Given this list of marker genes RNFT2, CD5L, TNMD, TINAG, ELMOD1, REEP5, XPOT, SAP18, LRRC8E, SF3B2, DPF1, HRH4, COLCA1, ZFP69, TTBK2, CLCN5, NHSL3, FAM89A, CDKL4, CLDN16, NPY1R, CALHM2 (calcium homeostasis modulator family member 2), CYP4V2, GSTO1, ZNF365, RPL27, SLC16A2, LPCAT1 (lysophosphatidylcholine acyltransferase 1), CYP3A4, KRT23, ASPM, COX7A2, MTCL1, KRTDAP, PIK3R6, CYFIP1, PAM, PNMT, WNT5A, LYPLAL1, TP53I11, AGMO, RAD51, EBI3, NME1 (NME/NM23 nucleoside diphosphate kinase 1), RNF11, RTL5, NTNG1, SMIM30, PXYLP1, CHL1, SLC22A14, GPLD1, CSDC2, ZDBF2, KRTAP8-1, ELAVL2 (ELAV like RNA binding protein 2), ZBTB18, NDNF, WDR83OS, VASH1, ESRRB, SPAG16, SH2D1A, CYP20A1, EGR3, ARHGAP28, BMP7, LGALS3, SMPDL3B, BCAT1, MELK, ALDH1L2, SYCP1, IGLON5, ANAPC13, DYNLL1, SQOR, STMN1, ASF1B, NDUFB9, PACC1, FKBP9, CNPY2, SLITRK4, NDUFV2, DNAH9, ZNF35, CCDC83, SCIN, PLPPR5, HDGF, TRIM3, MXRA7, SBK1, IFITM2 (NCBI Gene Id 10581), GCNT2, DGLUCY, EHF, NDUFA12, ITGB1, NRGN, TLR3, GLRX5, CRIP1, DLK1, MAP3K9, STON1, SLAMF6, EOMES, AMPD3, ARID3B (AT-rich interaction domain 3B), MPC2, NIPSNAP3A, TASL, CD22, KCNK13, TMC8, KLHDC3, NDUFB2, CRYZ, L1CAM, POU2AF1, LIPA, OPN3, JAM2, AGXT2, ARHGEF12, PLXDC2, MFSD2B, ATP1B2, PRDX1, PTGR1, C6, CEP55, GNA14, SEMA4A, API5, SHH, DGKI, C4orf46, KCNJ15, NECAB1, KRTAP17-1, CA12, KIF22, TXN, SATB2, EML6, LCE2B, TXNDC12, AP1S3, LPCAT4, CPT1A, TIAM1, GFI1B, SLC22A25, TNFRSF4, IKZF4, FSTL5, SLC35D3, MRPL51, BAD, NDUFB7, ACO1, PLP2, ESM1, RNF168, SLC7A10, GLTP, CD81, TMEM120B, CAPSL, LHX2, POLR1D, CD80, KGD4, CENPP, SUPT16H, KANK2 (KN motif and ankyrin repeat domains 2), CAPZB, SLC15A3, NRSN1, CFI, CSF1, GNB4, ZNF385A, SNAI2 (snail family transcriptional repressor 2), ATP1B4, IGFBP5, FCGRT, NKX2-2, RALY, SH3BGRL2, NALCN, ARMCX4, SNRPB, EFR3B, KPNA2, ERC2 (ELKS/RAB6-interacting/CAST family member 2), here is a description of the gene set: studied in species Homo sapiens Human Gene Set: GSE20366_EX_VIVO_VS_HOMEOSTATIC_CONVERSION_NAIVE_CD4_TCELL_DN Regulatory T (Treg) cells that express the FoxP3 transcription factor are essential for lymphoid homeostasis and immune tolerance to self. Other non-immunological functions of Treg cells, such as controlling metabolic function in adipose tissue, are also emerging. Treg cells originate primarily in the thymus, but can also be elicited from conventional T cells by in vivo exposure to low-dose antigen or homeostatic expansion, or by activation in the presence of TGFβ in vitro. Treg cells are characterized by a distinct transcriptional signature controlled in part, but not solely, by FoxP3. For a better perspective on transcriptional control in Treg cells, we compared gene expression profiles of a broad panel of Treg cells from various origins or anatomical locations. Treg cells generated by different means form different sub-phenotypes identifiable by particular combinations of transcripts, none of which fully encompass the entire Treg signature. Molecules involved in Treg effector function, chemokine receptors, and the transcription factors that control them are differentially represented in these subphenotypes. Treg cells from the gut proved dissimilar to cells elicited by exposure to TGFβ, but instead they resembled a CD103+Klrg1+ subphenotype preferentially generated in response to lymphopenia. from publication Feuerer M, Hill JA, Kretschmer K, von Boehmer H, Mathis D, Benoist C (PMID 20231436) Genes down-regulated in comparison of TconvLP versus Homeo Foxp3- (see Table 1S in the paper for details).